Given this list of marker genes GPR15, LPCAT3, ITIH2, SLC49A3, RPS6, MAMLD1, SARAF, MAL, HDHD3, LYRM4, ST6GALNAC4, EIF2D, RIOX1, DHPS, ITK, NPDC1, CAMK2N1, GJA9, TRGV5, FBLN5, HMGA1, LY9, CAB39, FLT3LG, SNHG20, PLEKHB1, CD27, CD248, NR3C2, EPS8L2, RLN2, RSL1D1, GLOD4, USP13, SRP14, PTPN3, LEF1, INSL3, RPL19, IL7R, THPO, ODC1, S100A3, RPL34, DYNLT3, ST13, CD5, TBX2, GRSF1, PASK, DNAJB1, CCNE1, ACTR1B, CAD, NOSIP, AKIP1, LRRN3, PAFAH1B3, KDSR (3-ketodihydrosphingosine reductase), ADPRM, TBCC, CBR3, BCAT2, ZNF550, UBE2G1, RGS10, FKBP5, DKC1, INPP4B (inositol polyphosphate-4-phosphatase type II B), GRPR, DELEC1, LTB, YBX3, MOSPD1, CNN2, DSC1, ZFAND1, PKIA, SPATA7, EIF4A2, AIP, RGS14, CCR7, TRMT11, POLM, SIT1, SRSF5, LRFN3, DXO, CAMK4, ATP13A1, FCGRT, ABCD2, SYPL1, ZDHHC6, GCFC2, GNB5, COPZ1, CCNB1IP1, ID3, LRRC8B (NCBI Gene Id 23507), CNOT7, MEAF6, PRKRA, RPS3 (NCBI Gene Id 6188), TTC9, TRBC1, CASP6, EZR, TRAV12-2, TNFSF8, CEP68, SIRPG, NELL2, NCK2 (NCBI Gene Id 8440), LIME1, MALT1, BAG5, PALS2, DPP4, PBXIP1, LRP6, BAG2, PRPS1, SMYD5, KBTBD4, PRORP, OCM2 (NCBI Gene Id 4951), BAG3, ERGIC3, EPHX1, PABPC4, DGKA, ARHGAP15, LSR, TBC1D4, SLAMF1, MAP4K2, ADARB1, CNTRL, SCMH1, ATP1A1, LRCH4, PLPP1, KRT14, TMEM204, SIN3B, MPI, CD3G, UBASH3A, RPL10L, PLPPR3, AMD1, GPRASP1, TRAC, RPS10, TMEM63A, CDKN2AIP (NCBI Gene Id 55602), VIPR1, AKAP1, DNAAF5, ATP6V1B1, OSBP2, PTPRO (NCBI Gene Id 5800), ADK, THAP4, LDLRAP1, ZNF706, TOMM20, PRKCA, FAM171A1, ABCC1, FDX1, CDR2, CD28 (NCBI Gene Id 940), RENBP, PYGB, CD3E, RNF216, NRCAM, CD8B, ESD, TPT1P8, FGF9, TACC3, HIGD2A, DRG1, RETREG1, GGT1, PGAP2, PHF1, PEBP1, NDFIP1, UXS1 (NCBI Gene Id 80146), ICOS, LDHB, TMED3, MCAT, here is a description of the gene set: Immune cell-specific expression is one indication of the importance of a gene's role in the immune response. In order to identify such patterns, we set out to broadly profile gene expression in a variety of immune cells. Human Gene Set: GSE22886_NAIVE_CD8_TCELL_VS_NKCELL_UP Genes up-regulated in comparison of naive CD8 T cells versus unstimulated NK cells. studied in species Homo sapiens from publication Abbas AR, Baldwin D, Ma Y, Ouyang W, Gurney A, Martin F, Fong S, van Lookeren Campagne M, Godowski P, Williams PM, Chan AC, Clark HF (PMID 15789058)